The following is a description of a gene set: species: Homo sapiens EPHA-mediated growth cone collapse Human Gene Set: REACTOME_EPHA_MEDIATED_GROWTH_CONE_COLLAPSE, and this is the list of marker genes: EPHA8, EPHA1, EFNA3, MYL12B, EPHA2, RHOA, MYH10, EPHA10, ROCK2, MYH14, EPHA4 (EPH receptor A4), ROCK1, EPHA5, MYH9, EFNA2, LYN, EPHA6, FYN, SRC, EFNA1, EPHA3, EFNA4, EFNA5, MYL6, YES1, MYL9, MYH11, NGEF, EPHA7